Given this list of marker genes ZNFX1, UBE2A, ACSL3, JPT2, EML4, CD40, MAF, YIPF6, TANK, RMI1, HHLA2, GON4L, FAM120B, IFNAR2, ZHX2, KYNU, HSPH1, ACOX1, FLVCR2, ABCC3, NLK, EIF2B5, SLC43A2, HSPA8, SAV1, MTCH2, TRIM55, RNF34, NMRAL2P, HDGF (heparin binding growth factor), PDGFC, PHF13, KLHL22, TJAP1, IL2RG, SDF4, FAM98A, HEXIM1, EPOP, EED, TNFRSF18, BTBD7, RAD1, ATP6V0E1, ZNF274 (zinc finger protein 274), DYNLL1, SPAG9 (NCBI Gene Id 9043), PDZD11, METTL1, CTNS, CD63, ANAPC7, NLRC4, CES1, ZNF513, MRPS31, SLC3A2, ZFYVE1, ABCC1, TNFRSF4, TMED9, TRAF3, PSMC1, CYP1B1, SOWAHC, HSPB1, CD82, VASP, ZSCAN29 (NCBI Gene Id 146050), SLC26A11, GRIA2, NFE2L2, ZNF267, MFSD2A, ATP6V1C1, TMEM199, ZNF410, PPARD, GPR35, ZMIZ1-AS1, G6PD, FUS, FADS2, CCRL2, YRDC, MRPL27, PCLAF, GAS2L3, DNAJA1 (NCBI Gene Id 4737), VPS50, LINS1, DNAJC6, DNAJB6, RAB39A, CD276, TUBB4B, HPS5, XPO5, IGF2R, PLPP5, GPX4, SDC4, IL18R1, CFLAR, THAP1, FADD, NMT2, MGLL, SERPINB8, RER1 (NCBI Gene Id 11079), TNFRSF10D, TTC9C, DCAF1, GSR, SPATS2L, SART3, LAMTOR3, ZNF664, IL10RB-DT, SLC41A2, LCMT2, MED31, HSP90AA1, TMEM138, ATP6V1B2, FAF2, RARS1, KCTD11, LPIN1, RNF185, ADAT3, TM2D2, MAMLD1, PSMD11, MED8 (NCBI Gene Id 115853), SLC25A3, STX4, LPAR1, PTPRJ, SLC12A6, TPD52, TJP2, BMAL2, PSEN1, WDR1 (WD repeat domain 1), CYP51A1, VDAC3, BTG3, PDXK, BIRC3, ZNF200 (zinc finger protein 200), NIBAN2, SACS, MRPL20-AS1, PITPNA, TMEM208 (transmembrane protein 208), ATP6V0A1, TUBB6, YAE1, MSC, MSMO1, ZNF691, EMP1 (epithelial membrane protein 1), GPN2, PSMD1, SP4, HSD11B1, CCNA1, LRP12, IPO9, SLC35B2, SPRED2, CRNKL1 (crooked neck pre-mRNA splicing factor 1), ATP13A3-DT, ACVR2A, ZNF697, IL3RA, PCID2, ZNF140, NEU1, TXLNA, WSB2, ARHGEF2, TNIP1, ZBTB42, TNPO3, KMO, C1QB, MOB3C, DAB2, PSMA3, HIP1, VCP, TARDBP, SIGLEC17P, ADAM17, SENP5, NPC1, USF3, here is a description of the gene set: Th1 and Th2 cells arise from a common precursor cell in response to triggering through the TCR and cytokine receptors for IL-12 or IL-4. This leads to activation of complex signaling pathways, which are not known in detail. Disturbances in the balance between type 1 and type 2 responses can lead to certain immune-mediated diseases. Thus, it is important to understand how Th1 and Th2 cells are generated. To clarify the mechanisms as to how IL-12 and IL-4 induce Th1 and Th2 differentiation and how TGF-beta can inhibit this process, we have used oligonucleotide arrays to examine the early polarization of Th1 and Th2 cells in the presence and absence of TGF-beta after 0, 2, 6 and 48 hours of polarization. Genes down-regulated in CD4 T cells activated by anti-CD3 and anti-CD28: IL4 (6h) versus untreated (6h). species: Homo sapiens from publication Lund R, Aittokallio T, Nevalainen O, Lahesmaa R (PMID 14607935) Human Gene Set: GSE2770_IL4_ACT_VS_ACT_CD4_TCELL_6H_DN